The following is a description of a gene set: Reactome Pathway: Cell surface interactions at the vascular wall species: Homo sapiens part of: Hemostasis Leukocyte extravasation is a rigorously controlled process that guides white cell movement from the vascular lumen to sites of tissue inflammation. The powerful adhesive interactions that are required for leukocytes to withstand local flow at the vessel wall is a multistep process mediated by different adhesion molecules. Platelets adhered to injured vessel walls form strong adhesive substrates for leukocytes. For instance, the initial tethering and rolling of leukocytes over the site of injury are mediated by reversible binding of selectins to their cognate cell-surface glycoconjugates.<p> Endothelial cells are tightly connected through various proteins, which regulate the organization of the junctional complex and bind to cytoskeletal proteins or cytoplasmic interaction partners that allow the transfer of intracellular signals. An important role for these junctional proteins in governing the transendothelial migration of leukocytes under normal or inflammatory conditions has been established.<p> This pathway describes some of the key interactions that assist in the process of platelet and leukocyte interaction with the endothelium, in response to injury., and this is the list of marker genes: L1CAM, ITGAV, ATP1B1 (NCBI Gene Id 481), ATP1B2, FCAMR (NCBI Gene Id 83953), CD99L2, IGLV4-3, PSG5, SLC16A1, IGLL1, GRB14, PPIL2, SHC1, IGHV2-70, GYPB, PSG4, SLC16A8 (NCBI Gene Id 23539), PTPN11, SIRPG, PROC, CD177, IGLV7-43, IGHV1-69 (NCBI Gene Id 652126), ATP1B3, SELL, IGLV4-69, SDC2, CD2, ITGA6, IGLV3-21 (NCBI Gene Id 28796), VPREB1, PF4, IGLV2-8, GYPA, eba1, IGLC7, IGLV4-60, IGLV2-14, PECAM1, HRAS, IGLV3-19, PSG8, PICK1, IGLV1-47, FCER1G, CEACAM8, THBD, IGLV3-12, IGLC2, PSG11 (pregnancy specific beta-1-glycoprotein 11), IGLV1-40, SPN, IGHV4-39, IGLV1-44, CD47, SDC4, PSG6, IGHV3-48, JAM2, F11R, IGHV2-5, opaE, IGLV10-54, SELE, opaH, IGLV5-45, IGKV5-2, IGKV2D-30, CD44, YES1, JAM3, TEK, IGKV2-29, ebl-1, SRC, F2, SLC3A2, VPREB3, COL1A2, IGLV, IGLV2-23, IGHV4-34, ITGB2, IGKV1-5, PIK3CB, PIK3R1, CD99, opaD, GLG1, opaC, FN1, APOB, opaF, IGKV3D-20 (immunoglobulin kappa variable 3D-20), PSG3, IGHV1-46, IGLV6-57, BSG, IGKV1-16, IGHV, IGHV3-13 (NCBI Gene Id 28449), IGHV3-11, PPIA, PIK3R2, PSG9, GYPC (glycophorin C (Gerbich blood group)), ITGA5, IGHV3-9, CD244, opaA, SLC7A6, ITGA4, IGHV3-33, IGLC1, CEACAM5, PTPN6, IGLV1-36, PSG2, IGLV3-16, EPCAM (NCBI Gene Id 4275), CEACAM6, SLC7A9, IGKV3-20, IGHV7-81, ITGAM, ANGPT1, opaK, TNFRSF10B, opaG, NRAS, CD48, IGLV3-22, IGKV2D-40, IGKV1D-16 (NCBI Gene Id 28901), IGKV1-17, ITGB3, SDC1, IGLV1-51, SIRPA, LYN, ITGA3, PLCG1, PIK3CA, IGHV3-7, PROCR, IGLV5-37, IGLV3-25, DOK2, SOS1, MMP1, INPP5D, IGLV7-46, SLC7A10, MAG, IGHA2, TGFB1, IGLV2-18, GRB2 (NCBI Gene Id 80715), GP6, IGLV2-33, MERTK, PF4V1, TREM1, IGKV1D-39, SLC7A5, CEACAM1 (CEA cell adhesion molecule 1), OLR1, JCHAIN, IGLV11-55, KRAS, LCK, CD84, PSG7, IGLV3-27 (immunoglobulin lambda variable 3-27), IGKV1-33, IGKV1D-33, IGLV2-11, FYN, SLC7A11, SLC7A8, IGLC3, IGHM, IGKV3-11, GRB7, CD74, IGHV1-2, IGLC6, JAML, SELP, MIF, IGKV2D-28 (immunoglobulin kappa variable 2D-28), TNFRSF10D, PSG1, TNFRSF10A, IGHV4-59, ANGPT4, IGHV3-23, opaI, COL1A1 (collagen type I alpha 1 chain), ITGAL, ITGAX (NCBI Gene Id 3687), IGKV2-28, IGKV2-30, SDC3, IGKV3-15, ANGPT2, CAV1, CD58, IGKV4-1, GAS6, IGKC, ESAM, SLC16A3, TSPAN7, ITGB1, IGKV1D-12, IGHA1, piiC, SLC7A7, PROS1, CEACAM3, IGKV1-12, IGLV8-61, opaJ, eba-140, IGHV3-30, GPC1, opaB, IGHV3-53, IGLV3-1, IGKV1-39, SELPLG, CXADR